Given this list of marker genes Magt1, St6gal1, Rft1, Mgat1, Derl3, Fut8 (fucosyltransferase 8), Dhdds, Dpagt1, Alg2, Mgat2, Tusc3, Alg13, Alg6, Uggt2, Stt3b, Alg8, Alg12, Alg14, Ost4, Nus1, Dpm1, Alg11, Ddost, Alg1 (ALG1 chitobiosyldiphosphodolichol beta-mannosyltransferase), Ube2j1, Stt3a, Alg10b, Mgat5 (NCBI Gene Id 98381), Uggt1, Alg9, Srd5a3 (NCBI Gene Id 78351), Rpn1, Dad1, Alg3, Alg5, here is a description of the gene set: The glycosylation of protein via the N4 atom of peptidyl-asparagine forming N4-glycosyl-L-asparagine; the most common form is N-acetylglucosaminyl asparagine; N-acetylgalactosaminyl asparagine and N4 glucosyl asparagine also occur. This modification typically occurs in extracellular peptides with an N-X-(ST) motif. Partial modification has been observed to occur with cysteine, rather than serine or threonine, in the third position; secondary structure features are important, and proline in the second or fourth positions inhibits modification. Mouse Gene Set: GOBP_PROTEIN_N_LINKED_GLYCOSYLATION_VIA_ASPARAGINE species: Mus musculus